The following is a description of a gene set: Human Gene Set: GSE3982_NKCELL_VS_TH2_UP species: Homo sapiens from publication Jeffrey KL, Brummer T, Rolph MS, Liu SM, Callejas NA, Grumont RJ, Gillieron C, Mackay F, Grey S, Camps M, Rommel C, Gerondakis SD, Mackay CR (PMID 16474395) In the present study we used Affymetrix oligonucleotide microarrays to produce gene transcription profiles for the major leukocyte types in humans. This comprehensive dataset enabled us to not only establish which genes were expressed in each leukocyte type, but also which genes were expressed in each subset after activation. The used of a comprehensive dataset of gene profiles from all the major human leukocyte subsets enabled a novel and powerful means for identification of genes associated with single leukocyte subsets, or different immune paradigms. Genes up-regulated in comparison of NK cells versus Th2 cells., and this is the list of marker genes: ZNF143, DAZAP2, ANXA1, UBAP1, PAK3, TPP1, EDNRB, MYO15B, ZNF862, TJAP1, GPR4, ERBB2, ZNF34 (NCBI Gene Id 80778), INAVA, PDE6G, ACTN2, INPP4A, C4orf19, KCNJ1, MANBA, JADE2, SLC25A21, IL7R, CXCL12, SYK, STOM, GPR27, PPARA, KCNJ12, H2AP, MIP, GLUL, SLC27A3, SH2B2, MICALL1, UPK3A, APOBEC3G, AGPAT4, LZTS1, ABL1, WDR37 (NCBI Gene Id 22884), LTBP2, CAMKMT, TRIM22, FRMD4A, FCER1A, VEGFC, PCDHGB5, GYS2, KLRC3, C5AR1, RNF31, CYB5R1, RSAD1, CAMLG, PRODH2, LRAT, PDXDC1, PSG3, FAM53B, S100B, CPA4, RPRD2, ACTL8, GPBP1L1, HECTD3, LINC01278, HK3, TBKBP1, SNN, PTX3, B4GALT6, MFAP5, RAC2, YPEL1, FCHSD2, PROCR, MTCL1 (NCBI Gene Id 23255), KLF4 (KLF transcription factor 4), NRG1, LILRA3, DRAM1, DCUN1D2, EFEMP2, LRP10, IL1RAPL1, UBE2D4, NBR1, FMO6P, ACSS3, ZBP1, PDGFD, FBXO34, PCOLCE2 (procollagen C-endopeptidase enhancer 2), MIR622 (NCBI Gene Id 693207), ARHGEF3, F2RL3, ARSF, CYRIA, IGHA1, ENPP4 (ectonucleotide pyrophosphatase/phosphodiesterase 4), CLEC1A, JAG1, GPR21, EPS8L1, DNAI2, BDKRB1, TAAR3P, CEBPA, RORC, MX2, KLRB1, TPM1, CD160, KLF12, KIFAP3, NISCH, BSN, SPON2, AOAH (NCBI Gene Id 313), CAND2, WASF2, TMEM127, SULT4A1, PZP, RNF44, IL1B, RASL11B, TXK (TXK tyrosine kinase), HRH3, POMZP3, AVPR1A, IL5RA, PLEKHM1, NPR3, RAB36, SYNE2, TMSB15A, IMPACT, DHRS7, SYCP1, SLC10A3, HLA-C, CNKSR2, CDC37L1, NEIL1, NFKBIL1, F9, RBM12B, HTR3A, FYN, CLEC10A, VAV3, LINC00623, ZBTB44, TSC22D1, PTPRE, MAST3, MTARC2, LCOR, STOML1, SPTBN5 (NCBI Gene Id 51332), SSUH2, GABRR2, PLEKHF1 (pleckstrin homology and FYVE domain containing 1), XKR8 (NCBI Gene Id 86422), FMO3, GSTT2, HOXA11, CD44, HLA-DPA1, EDNRA, RGS19, GAD2, ANTXR1, PIP4K2B, POM121L2, CALCOCO1, USP19, ZZEF1, MAU2, ITGAL, ZNF440, WFDC1, DPPA4, KLHDC8A, RXRA, SAP30L-AS1, GPR25, DENND3, AK1, TCTA, UBE4B, PGR, ENC1, CD207, RNF220